Given this list of marker genes Rpusd4, Dkc1, Wtap, Pus7l, Adarb1, Pus7, Bag4, Pus1, Dnajb11, Rpusd2, Mettl14, Trub2, Hnrnpab, Mettl3, Hnrnpc, Apobec2, Apobec1, A1cf, Trub1, Syncrip, Pus3, Rpusd3, here is a description of the gene set: The covalent alteration of one or more nucleotides within an mRNA molecule to produce an mRNA molecule with a sequence that differs from that coded genetically. studied in species Mus musculus Mouse Gene Set: GOBP_MRNA_MODIFICATION